The following is a description of a gene set: Reactome Pathway: Chromatin organization Eukaryotic DNA is associated with histone proteins and organized into a complex nucleoprotein structure called chromatin. This structure decreases the accessibility of DNA but also helps to protect it from damage. <br><br>The 'building block' of chromatin is the nucleosome. This contains ~150 bp of DNA wrapped around a histone octamer which consists of two each of the core histones H2A, H2B, H3 and H4 in a 1.65 left-handed superhelical turn.<br><br>Most nucleosome assembly occurs in a coordinated fashion during DNA replication, with histone deposition occurring on newly synthesized DNA. Local changes in chromatin organization are required for transcription, DNA repair, regulation of gene expression and other processes. The accessibility of DNA is regulated by chromatin modifying enzymes that deposit post-translational epigenetic marks on histones and DNA and by ATP-dependent chromatin remodellers that use the energy of ATP to assemble, rearrange and reposition nucleosomes. studied in species Homo sapiens, and this is the list of marker genes: MSL2, NCOA2, MCRS1, PRMT7, PAF1, H2AC4, BCL7C, KMT5A (NCBI Gene Id 387893), SETD3, UTY, COPRS, TADA2A, KAT8, FAM124B, MBD3, ATF7IP, AEBP2, SNRPD1, KDM6A, GATAD2A, TCF4, SETD1B, SETDB1, ZNF592, ATF2 (NCBI Gene Id 1386), NFKB1, KDM4A, PRDM16, ACTL6A, MRGBP, NCOR1, BCL7B, SUV39H1, BCL7A, SF3B6, TCF12, H2BC26, PRDM9, PHF6, PRMT3, KDM3B, H2BC1, SUPT3H, MTA2 (metastasis associated 1 family member 2), WDR5, TAF12, BICRAL, PRMT1, G6PC1, TAF10, ARID1A, CHD7, HMG20B, H2BC5, BRD8, H2BC15, MSL1, H2AC21, SF3A3, TAF5L, SMARCA2, H2AC6, KDM2A, EP400, CHD3, BRPF1, MBD2, H2BC17, KDM5B, SETD2, SF3B4, SNRPA1, VPS72, IGF2, SMARCD1, PADI6, REST, TAF6L, HDAC8, ENY2, H2AC20, H3C15, KMT2D, NR2C2, ZZZ3, CARM1, DPF1, MSL3, TBL1XR1, ELP5, SETD7, CDK4, SKIC8, BRPF3 (NCBI Gene Id 27154), PA, H3-3A, RBBP4, KDM4C, SNRPN, MTA1, CHD1, SAP30, RBM17, PWWP2A, EZH2 (NCBI Gene Id 392834), KDM4D, BRD9, SMARCE1, EPC1, TCF19, H2BC4, GATAD2B, SETDB2, H2AC11 (NCBI Gene Id 8969), SMARCD3, CBX3, TADA3, H2AC1, HAT1, H2AB1, LEO1, PADI4, ELP6, BRMS1, ELP4, MBD3L1 (NCBI Gene Id 85509), H2AC14, PCK1, MORF4L1, SS18, KDM3A, CDK2AP1, SNRPB, EHMT1, TAF9, NFE2L2, RELA (NCBI Gene Id 5970), H3C1, KANSL2, SF3A2, CBX1, CHD2, ATXN7L3, FBP1, SETD6, NQO1, KAT6A, JADE2, KAT7, NSD3, MORF4L2, KAT5, ELP1, ELP2, ELP3, ASH1L, KDM1B, H2AZ2, RUVBL2, H2BC13, H2BC18, H2BC21, BRD7, HCFC1, MBIP, NKD2, SF3B5, MEAF6, SNRPE, PHF5A, NP, SNRPG, ARID4B, H2AC25, BRD1, SMARCB1, HDAC2, ATXN7, IKZF3, CDK2AP2 (NCBI Gene Id 10263), SUPT7L, JADE3, DHX15, TCF3, ZNF687, SF3B1, DPF3, PWWP2B, H2AX, KMT5B, HDAC10, GPS2 (G protein pathway suppressor 2), ARID2, PHF8, JMJD6, NSD2, AXIN2, MBD3L2, H2BC11, TADA2B, TADA1, PB1, MAFK, H2BC3, BCL11B, MYOD1, DMAP1, SMARCC2, KMT2A, SUPT16H, ZNF827, USP22, SMARCC1, PADI2, NCOA1, H2BC12, BCL11A, DKK2, DOT1L, CCND1, KDM1A, MTA3, SF3A1, SNRPD2, KAT14 (lysine acetyltransferase 14), CDC73, ING4, NFKB2, DPF2, KDM4B, UBE2I, DDX42, SUDS3, KMT5C, NR2F2, RBBP7, IKZF1, KAT2B, KANSL3, ACTL6B, CHD8, ADNP, YEATS4, ING3, DPY30, SUPT20H, ZNF532, SAP18, SAP130, CLOCK, PHF21A, RIOX2, CTNNB1, KAT6B, PAX3, PUF60, SUMO1, CHERP, EHMT2, IKZF2, H2BC12L, KDM5D, SNRPD3, ACTB, SETD1A, SNRPF, DNMT3A, SMNDC1, TBL1X, SMARCD2, SS18L1 (NCBI Gene Id 26039), KDM5A, SSRP1, RBBP5, CHD9, ZMYND8, PBRM1, MECOM, ASH2L, PADI1, HDAC1, ARID5B, CHD4, SUZ12, RPS2, RTF1, PHF2, CREBBP, SMYD2, OGT, PRMT5, KDM7A, KDM5C, H2BC9, H2AJ, PRMT6, DDX46, PHF10, CTCF, YEATS2, H2AC7, H2BC14, SUV39H2, KDM2B, KMT2C, PB2, U2SURP, SF3B2, HDAC3, CHD5, SF3B3, EP300, KDM6B, MYOG, SNRPB2, NS, PADI3, KAT2A, SGF29, DR1, PHF20, KANSL1, H2AC12, ARID1B, SAP30L, CHD6, BRWD1, H2AC18, NCOR2, ARID4A, SMYD3, JADE1, KMT2B, TRRAP, ING5, SMARCA4, WDR77, RUVBL1, NSD1, CTR9, JAK2, EED, BICRA, ADNP2, H4C1, RCOR1